Given this list of marker genes Ulk1, Armc10, Arf2 (ADP-ribosylation factor 2), Shisal2b, Pigf, Fam220a, Mrps31, Tle1, Tepsin (NCBI Gene Id 78777), Trp53rkb, Pidd1, Dffb, Ppp2r5d, Dyrk3, Slc25a12, Cldn2, Fgf18, Gpn3, Usp27x, Limk2, Wdr73, Fdxr, Isg20, Ubd, Zfp64, Atp23, Spryd4, Elovl5, Depdc7, L3hypdh, Ovgp1, Polr1e, Cluap1, Ttc23, Adal, Sac3d1, Brinp1, Gm42921, Zfp622, Fbrs, Nsmce2, Rbm43, Ift43, Ephb3, Rprm, Tmem41a, Trmt61b, Natd1, Tas1r2, Msh6, Naa30, C630043F03Rik, Twist2, Sec24d, Crisp2, Traf4, Otud4, Knop1, Ccnt1, Hilpda, Zfpm1, Sap30, Ddit3, Zfp125, Def6, Btg2, Sap30bp, Slc7a6os, Trim13, Zxdc, Gpr84, Btg1, Cdan1, Pnp, Kin (Kin17 DNA and RNA binding protein), Fbxo17, Hmgcl, Prss3b, Ddx41, 2310057M21Rik, Fastkd3, Tgif1, Caml, Sh3yl1 (Sh3 domain YSC-like 1), Gmip, 2810001A02Rik, Dcaf4, Imp3, Casp6, Mtres1, Zfyve21, Lpin1, Fchsd1, 2900052L18Rik (NCBI Gene Id 76835), Chst11, Mterf4, Ppm1d, Rap2b, Arvcf, Mrm1, Icam1, Dusp11, Zfp263, Cmtm6, Ptk2, Ptcd1, here is a description of the gene set: from publication Bruins W, Bruning O, Jonker MJ, Zwart E, van der Hoeven TV, Pennings JL, Rauwerda H, de Vries A, Breit TM (PMID 18195040) Middle response genes: differentially expressed in the period between 3 h and 12 h after UV-C irradiation of MEF cells (embryonic fibroblast). Mouse Gene Set: BRUINS_UVC_RESPONSE_MIDDLE Phosphorylation is important in p53-mediated DNA damage responses. After UV irradiation, p53 is phosphorylated specifically at murine residue Ser389. Phosphorylation mutant p53.S389A cells and mice show reduced apoptosis and compromised tumor suppression after UV irradiation. We investigated the underlying cellular processes by time-series analysis of UV-induced gene expression responses in wild-type, p53.S389A, and p53(-/-) mouse embryonic fibroblasts. The absence of p53.S389 phosphorylation already causes small endogenous gene expression changes for 2,253, mostly p53-dependent, genes. These genes showed basal gene expression levels intermediate to the wild type and p53(-/-), possibly to readjust the p53 network. Overall, the p53.S389A mutation lifts p53-dependent gene repression to a level similar to that of p53(-/-) but has lesser effect on p53-dependently induced genes. In the wild type, the response of genes to UV irradiation was strictly biphasic. The early stress response, from 0 to 3 h, results in the activation of processes to prevent the accumulation of DNA damage in cells, whereas the late response, from 12 to 24 h, relates more to reentering the cell cycle. Although the p53.S389A UV gene response was only subtly changed, many cellular processes were significantly affected. The early response was affected the most, and many cellular processes were phase-specifically lost, gained, or altered, e.g., induction of apoptosis, cell division, and DNA repair, respectively. Altogether, p53.S389 phosphorylation seems essential for many p53 target genes and p53-dependent processes. species: Mus musculus